The following is a description of a gene set: Normal cells require continuous exposure to growth factors in order to cross a restriction point and commit to cell-cycle progression. This can be replaced by two short, appropriately spaced pulses of growth factors, where the first pulse primes a process, which is completed by the second pulse, and enables restriction point crossing. Through integration of comprehensive proteomic and transcriptomic analyses of each pulse, we identified three processes that regulate restriction point crossing: (1) The first pulse induces essential metabolic enzymes and activates p53-dependent restraining processes. (2) The second pulse eliminates, via the PI3K/AKT pathway, the suppressive action of p53, as well as (3) sets an ERK-EGR1 threshold mechanism, which digitizes graded external signals into an all-or-none decision obligatory for S phase entry. Together, our findings uncover two gating mechanisms, which ensure that cells ignore fortuitous growth factors and undergo proliferation only in response to consistent mitogenic signals. from publication Zwang Y, Sas-Chen A, Drier Y, Shay T, Avraham R, Lauriola M, Shema E, Lidor-Nili E, Jacob-Hirsch J, Amariglio N, Lu Y, Mills GB, Rechavi G, Oren M, Domany E, Yarden Y (PMID 21596316) Human Gene Set: ZWANG_EGF_PERSISTENTLY_UP species: Homo sapiens Genes persistently induced by EGF in 184A1 cells (mammary epithelium)., and this is the list of marker genes: POR, PRUNE2 (prune homolog 2 with BCH domain), TCEA2, CYP51A1, OASL, HSDL2, ACSS2, SERPINB7, RNF216, FAM98A, OGDH, RNF227, RBFOX1, ERG28, CCDC149, CALU, CPA4, IHO1, THAP12P1, KLHL7 (kelch like family member 7), NSDHL, RADX, IFIT3, UGDH, ME1, PUS10, SPMAP2L, RHOBTB2, LANCL2, IDI1, HMGCR, TMTC1, FAM169A, DYNC1LI1